The following is a description of a gene set: The chemical reactions and pathways involving N-acylphosphatidylethanolamines. An N-acylphosphatidylethanolamine is a phosphatidylethanolamine substituted at nitrogen by an acyl group. Mouse Gene Set: GOBP_N_ACYLPHOSPHATIDYLETHANOLAMINE_METABOLIC_PROCESS studied in species Mus musculus, and this is the list of marker genes: Napepld, Plaat5, Naaa, Abhd4, Plaat1, Pla2g4e, Plaat3